Given this list of marker genes FZD6, DNMT3A, RIN2, ZMAT3, IL13, CTTNBP2, SACM1L, KLF6, SGK3, LAMB4, CNTN3, LCORL, CYB561D2, ZBTB21, SGK1, NPNT, DMXL2, DENND1B, RAB5A, PI15, PRKD3, RANBP9, TRIM24, ZFAND4, SEPTIN11, ANXA10, CCNJ, PPARGC1B, SMARCD1 (SWI/SNF related, matrix associated, actin dependent regulator of chromatin, subfamily d, member 1), ANKRD11, SLAIN2, PAPOLG, ETNK1, MEIS2, MEX3B, SGPP2, ZBTB41, GALNT1, KIF3A, BBX, NEK7, MPP7, ZNF367, SCN8A, GABPB1, OTUD4, PIP5K1C, DLG5, WWTR1, PDE4D, ATOSA, DIPK2A, ATAD2B, ZNF827, PDE4A, PIKFYVE, TAB3, SPIRE1, CAV3 (caveolin 3), DIP2B, KCNJ6, BICD2, MAK, DUSP1, ABHD17C, TJP1, GRAMD4 (NCBI Gene Id 23151), BRPF1, DCAF7, CLDN11, MAGI1, KIF2A, CARNMT1, SOCS5, PURB, RFX4, EED, UNC79, TRPC4, FEM1C, DEGS1, OTUD3, PPP2R2A, LRP2, ERO1B, AP3S1, ATXN1, TBC1D12, MTOR, N4BP2, SUB1, ZNF385B, FUCA2, TSHZ3, CSRP2, RAB15, CREBRF, AP1G1, CPEB2, TFB2M, EYA1, CBFA2T2, NRK, CACNB2, EMP1, KDM3B, SLC7A11, UGGT1, KCNB2, DISC1, ANKRD17, CIR1, MTSS2 (NCBI Gene Id 92154), ARID1A, SINHCAF, ERBIN, CALCRL, ZNF532 (zinc finger protein 532), MTCL1, ZBTB5, SV2C, ASPN, MITF, GPATCH2, SELENOI, ATRX, NID2, CERS2 (NCBI Gene Id 63903), STMP1, UBE2A, ANKRD50, PIEZO1 (NCBI Gene Id 9780), JAKMIP2, SIX4, KIAA1586, FBN2, ADAMTS3, CAPS2, BICRA, NACC2, MED13, CCSER1, HIPK3, LRRC1, ARHGAP18, MAP3K13, SLC19A2, DAG1, POMP, HVCN1, NOTCH1, ARID5B, USP47, PNRC1, FOS, APP, MOB4, ROBO2, SLC30A7, HEY2, TBRG1, OPN3, CDH5, RIMBP2 (NCBI Gene Id 23504), UBE2D2, MBNL1, FKTN, DR1, SH3PXD2A, CXXC4, MTX3, SHISA6, AKT3, UBN2, NDFIP1, KLHDC1, RAB1A, AGA, FRYL, PURA, EZH2, GLCCI1, NEK4 (NCBI Gene Id 8380), C1orf52, NRCAM, STAG2, KLF2, TET2, TOGARAM1, ATXN1L, TMEM201, MRTFB, ZDHHC21, TULP4, PPTC7, SELENOT, SOX9, ZIC1, OBI1, PRKAA1, KBTBD8, MSI2, PRP4K, ZC3H11A, SSH1 (NCBI Gene Id 54434), GSK3B, LCOR, GJA1, ZNF749, KLF3, ZNF557, RCN2, ZCCHC2, VLDLR, LRAT, RAC1, ASAP1, ADAMTS17, EPHA5, TMEM65, MAPK6, PBX3, H2AZ2, ST7, KCNA1, MORN4 (NCBI Gene Id 118812), FBXW11, AJAP1, ITGA8, JDP2, CDK8 (cyclin dependent kinase 8), DIP2C, PPM1A, RXRB, TENT5A, AFAP1, NACA, PTBP3, SCN2A, FAM222B, ZSWIM6, MYCN, SALL1, USP38, CDKL5, ATP11B, IL1R1, MYO1E, NOVA1, ZNF451, NUP42, EMP2, CRISPLD1, POU4F2, RAB4A, CPEB3, NDST3, FZD4, HSPE1-MOB4, BTBD3, SLC12A2, NLK, CILK1, PCDH7, TIAM2, FAM114A1, STRN3, SLC25A3, BEGAIN (NCBI Gene Id 57596), ING3, CUL3, RORA, PURG, NSD1, BEAN1, RAP2C, MGAT4A, SYNCRIP, LGI2, RAB39B, PRKCE, TGFBR3, SEL1L, C8orf44-SGK3, ZEB1, ZFAND3, POGK, GID4, TNRC18, TGFBR1, MAPK1, PPFIA1, E2F8, GFRA1, RASD2, DSTYK, PCDH8, C9orf72, CCNT2, COL12A1, CHAC2, KIF5B, POLR3K, SLC1A1, ARAP2, UBE2D1 (ubiquitin conjugating enzyme E2 D1), THAP1, DDX3X, DCBLD2, PPFIA2, TAL1, KDM7A, NACA2, RNF111, MPHOSPH9, RNF38, MTMR2, KDM5A, ZBED4, RBM25, MSX1, ANKS1A, MAGI2, ZNF618, SPATA2, MLEC, MFSD6, EPN2, TGIF2, HIVEP3, PDS5B, MAP3K4, STC1, FBXW7, CBLL1, RASGRP3, SLC20A2, BCL9, PAFAH1B1, UBR3, SMARCA4, KDM6B, NAA15, SPRED1, PYGO1, ABHD17B, MARK1, BCL2L11, COL10A1, IQSEC1, CTNND2, MRGBP, MPPE1 (NCBI Gene Id 65258), FNDC3A, IPO8, TNPO1, GCLC, PPFIA4, CASTOR2, SPG11, HTRA3, APLP2, SLC39A10, TNRC6B, ZNF746, ATP2B2, AFDN, AEBP2, ENPP2, EVI5, ANKRD44, ACVR2B (activin A receptor type 2B), PTPN9, ABCC5 (ATP binding cassette subfamily C member 5), NEUROD1, PLXNA2, MIGA1, SH2B3, RFPL4B, CD86, PABIR3, SSBP2, SMARCA1, BDP1, FMNL3, CDYL, KCNH7, ENY2, ELOC, INO80D, ZBTB34, MAP3K9, AGGF1, PITPNB, PTCH1, ZFHX4, COTL1 (coactosin like F-actin binding protein 1), RALGPS2, PRICKLE1, GNB1, FGA, CEP350, PHACTR2 (NCBI Gene Id 9749), ADRB1, NFE2L2, KCNN3, ADAMTSL3, CEP126, ZDHHC20, ERO1A, FAM222A, PALM2AKAP2, CEBPA, GABRB2 (NCBI Gene Id 2561), ZBTB18, STAMBP, CAMTA1, REV3L, PSPC1, CHST12 (NCBI Gene Id 652072), FAT3, RAP1B, C8orf76, ZNF24, BMAL2, ARHGEF3, AGAP1, MORC3, FLRT3, ASCC3, NEMP2, SEMA3G, IFFO2, CADM2, CACNA1D, ANKRD28, MED14OS, SOCS2, KPNB1, PTGS2, SULT4A1, ADAMTS10, UTS2B, ATP5MC2, GLIPR1L1, LRCH2, GPR85, NR1D2 (nuclear receptor subfamily 1 group D member 2), VSX1, RFX3, GAB1, ZFP36L2, NPTX1, ATP1B1, MAML3, ZMYM2, ARHGAP17, SMARCA5, TFAP4, here is a description of the gene set: Human Gene Set: MIR101_3P from publication Chen Y, Wang X (PMID 31504780) Genes predicted to be targets of miRBase v22 microRNA hsa-miR-101-3p in miRDB v6.0 with MirTarget v4 prediction scores > 80 (high confidence targets). species: Homo sapiens